The following is a description of a gene set: Human Gene Set: WP_BDNFTRKB_SIGNALING BDNF-TrkB signaling species: Homo sapiens, and this is the list of marker genes: MKNK1, CREB1, GAB2, ARC, NTRK2, TSC1, RHEB, AKT1, RPS6KA1, MAPK1, GAB1, PIK3CG, MTOR, GRB2, SHC1, NRAS (NCBI Gene Id 4893), TRPC3, EEF2K, BDNF, ADCY1, HRAS, MAP2K1, GRIN1, RPS6KB1, EIF4EBP1, HOMER1, TRPC6, KRAS, SOS1, PLCG1, DLG4, BRAF, TSC2